The following is a description of a gene set: studied in species Mus musculus part of: Extracellular matrix organization Reactome Pathway: Non-integrin membrane-ECM interactions This event has been computationally inferred from an event that has been demonstrated in another species.<p>The inference is based on the homology mapping from PANTHER. Briefly, reactions for which all involved PhysicalEntities (in input, output and catalyst) have a mapped orthologue/paralogue (for complexes at least 75% of components must have a mapping) are inferred to the other species. electronically inferred by orthology from the curated human pathway, and this is the list of marker genes: Sntb2, Utrn, Sdc1, Sgce, Prkca, Vtn, Drp2, Itga2, Lama4, Sspn, Actc1, Fgf2, Sgca, Tgfb1, Sdc3, Sntb1 (syntrophin, basic 1), Itgb5, Col2a1, Sgcb, Col11a2, Dag1, Actg2, Sgcd, Col4a5, Col4a6, Acta1, Col4a2, Col5a3, Col10a1, Dtnb